Given this list of marker genes SMARCD3, MALT1, EFNB2, C7, IKBKB, EPG5, CD70, SHLD3, SLA2, PYDC5, NFKBIA, FCGR3A, KIR2DL4, IL16, BRD2, LILRA4, NPLOC4, XBP1, IRGM, IGHM (NCBI Gene Id 3507), MIR21, TYRO3, CASP6, MASP1, LBP, IL5, MYO18A, SHB, IL4I1, PIK3CD, ELP6, LRCH4, PRKCB, TACR1, BTN3A2, ZBP1, ACOD1, CSK, PCBP2, XRCC6, ZDHHC9, THY1, USP29, IPO5, CD4, CD7, BRCC3, SLAMF1, CD1E, ZNRF4, DPP4, NFKBIZ, AGER (advanced glycosylation end-product specific receptor), BANK1, CLCF1, CD40LG, EIF2B4, CD38 (NCBI Gene Id 952), GBP2, BTN2A1, PPP2R3C, C1R, GPR151, EBI3, TRAF6, STX4, HSPA8, MIR520B, HHLA2, CD247, CCR7, HMCES, EFNB1, TRIM41, LGALS9 (galectin 9), TAFA3, ARID1A, TRIM31, KLK7, S100A14, ZFP36L1, C5, MZB1, PLA2G5, FCGR1A, BTNL2, C1QBP, PYHIN1, CCR2, GCSAML, SQSTM1, F7, HEXIM1, HLA-DRB1, FBXL2, HDAC6, CD177, KRT1, OGT, BTNL8, TEC, PLA2G3, STAP1, IL7, PPT1, RTN4, MED23, PARP9, BTNL10P, SIRPG, PLA2G4A, ACTB (actin beta), MADCAM1, PLVAP, IL23R (NCBI Gene Id 94006), RBP4, ATAD5, PANX1, STAT5A, ZC3HAV1, CACNB3, MIR19A, POLR3G, PAXIP1, RAET1G, CD86, ULBP2 (UL16 binding protein 2), TRIM15, GPSM3, IKBKE, SMARCE1, DUSP10, KLRK1, PTPRC, CTSG, CXCL12, PTPRJ, C1S, POLR3F, NAGLU, MIR17, TRIM3, IRAK4, MAPKAPK3, RNF185, UBE2N, IGHG4, PPP3CA, C8G, PARK7, POLR3B, SPSB3 (NCBI Gene Id 90864), LAMP1, CLEC4E, BLK, FOS, LRRK2, TRAF3, FCRL3, NFKB1, KCNJ8, CD209, MIR149, EGR3, HLA-DQB2, NCK2, EIF2B1, ZNRF1, IL1R1, PRKCH, IL1A, DNM1L, GPR108, ALPK1, SOCS5, ITGA4, GPRC5B, ADAM17, LAT2, SMARCA4, EEIG1, MSTN, BRD4, SPHK2 (NCBI Gene Id 56848), IL17A, BANF1, PTK2, CCL1, MAP2K6, SHH, RC3H2, SMARCD2, GPATCH3, EVI2B, CPTP, SLC19A1, FYB2, HAVCR1, IL6R, STOML2, CD74, CD46, FPR1, ZDHHC4, ADAM10 (ADAM metallopeptidase domain 10), FZD5, LTF, RNF135, PELI1, AARS2 (alanyl-tRNA synthetase 2, mitochondrial), MIR210, TSLP, C2, DAPK2, PTN, ICOSLG, DDX41, RAC2, ZAP70, SOX4, BTN3A1, LAT, KITLG, CCDC88B, LAX1, PIK3CB, TCF3, EPO, CHUK, OASL, PLPP6, HLA-DQA2, ENPP3, MIR30B, TNFRSF21, TLR1, TLR7, TNFRSF13C (TNF receptor superfamily member 13C), MIR20A, POLR3D, ZCCHC3, ACTL6B, GDI1, FAM3D, GPR33, GATA2, CRLF2, SIVA1, TREM2, TRAF3IP3, MMP8, VSIR, F2RL1, FCGR2B, TNFRSF18, NFAM1, SWAP70, IL23A (NCBI Gene Id 51561), MED1, CXCL13, PARP1, ZBTB7B, STMP1, CD36, PRKD2, THEMIS, EIF2B3, RABGEF1, MIR136, TNFAIP3, B2M, IL6ST, HAVCR2, CYRIB (CYFIP related Rac1 interactor B), FPR3, LCK, XG, DUSP3, C8B, IFNL4, CX3CL1, LATS1, WDFY1, PPP2CA, XRCC5, SMARCC2, PNP, TRIL, UBASH3A, IGLC1, RIPK1, IFNB1, YWHAG, SCIMP, PPP6C, TNFRSF11A, PYCARD, ZDHHC5, FCAR, HCLS1, FCER2, GSDME, NEK7, C1RL, SOX13, CCL2, SPPL3, LACC1, IGF2, MAP3K7, FLOT1, TLR6, IL15, IGLC6, SMPDL3B, ERBIN, PHB1, FFAR3, MIR34A, BMI1, LRRC14, CD3D, SMARCA2, CD79B, CCL20, IGF1, SOS1, TGFBR2 (transforming growth factor beta receptor 2), FFAR2, TNFSF11, DUSP22, CCL8, SERPING1, IL10, IL36B, INAVA, CD244, CD300LB (NCBI Gene Id 124599), NOP53, CD5, KLRD1, FBXO38, LRRC19, IRF5, EXOSC3, HLX, TRIM6, JUND, MIR200B, ITGAM, IRF3, PCID2 (NCBI Gene Id 55795), TRIM62, ARID5A, ZDHHC12, PLA2G7, GPR32P1, MIR130A, CORO1A, PRKCA, TNFSF14, SH2B2, P4HB, FCN3 (NCBI Gene Id 8547), SPACA3, MEFV, CD1A, USP27X, KCNN4, JAK2, SPON2, CHRNB2, CD160, SLC9B2, TBK1, IFNL2, MASP2 (MBL associated serine protease 2), CTSS, RBM14, DDX3X, PRLR, C8A, PLA2G1B, C1QA, MIR140, UBR2, SMARCB1, TKFC, IL4R (NCBI Gene Id 3566), HLA-DRB3, IGHG1, CCL5, CCR1, NOD2, NCKAP1L, GLI2, ZP4, CD80, RASAL3, PTPN6, LGALS3, NR5A2, NOD1, LIPA, CD22, TNFRSF14 (NCBI Gene Id 93208), SELE, GLI3, SRC, CLEC7A, MAP3K8, MYD88, HLA-DQA1, RUNX3, SELP, LILRB4, ADA, EP300, GPR32, KCNK6, PRKCD, TGFB1, HLA-DPB1, PYDC1, CREBBP, RNF39, ELANE, KARS1, OCSTAMP, RNF125, GPR68, ITGA2, TRAF2, DDRGK1, FLT3LG, KAT5, DHX9, BCAR1, LCP2, C5AR2, IL12A, ABL2 (NCBI Gene Id 27), YES1, UBE2K, CD3G, PRKD1, MARK4, FCMR, EDN1, LGR4, IL18RAP, CAMK1D, TARBP2, CD8A, HLA-F, KLRC3, UBQLN1, PERP, PTK2B, STK11, IL12RB1, NR1H4, IL27RA, GPR65, LETMD1, SEC14L1, TIFAB, TRAT1, ZDHHC1, DHX58, ICOS, FADD, CD59, IKBKG, C1QC, CACTIN, TLR2, PIK3R6, JAM2, KHDRBS1, BCL6, SLC7A5, HSP90AA1, VAMP8, IGKC, PRKCZ, PVR, CD276, TRDC, HSPA1A, HLA-DRB5, BTN2A2, CBLB, PHF10, RAB7B, EDN2, MLH1, RIOK3 (RIO kinase 3), TRIB1, ATAT1, MTOR, SEMA7A, CD1D, IGHG3, CXCL10, TOMM70, FUT7, CCL3, ABHD17A, SASH3, MIR142, IL33, VAV1, VAV2, CD1C, SLC11A1, LPXN, TYROBP, CFB, STXBP1, TRBC1, ZP3, BST1, SLC15A4, LSM14A, IGHD, AKIRIN2, RFTN1, FCHO1, LILRB2, FYN, PDE4B, TRPV4, HLA-C, FOXJ1, LEF1, IL20, CD55, THBS4, ZNF580, MOSPD2, CAV1, PHB2, HLA-A, SHLD2, PLA2G6, NAGK, RAET1L, OTULIN, LAMP2, MOG, MS4A1, IGHE, CLPB, GPR31, RPL13A, TNFRSF4, CPT1A, VNN1, BTK, NMI, PIK3R1, ZMIZ1, IRF4, FCN1, RIGI, GPLD1, KLRC4-KLRK1, TOX, ASCL2, PAK1, A2M, ID2, LEP, RELA, PHPT1, CD2, IFNK, IGLC7, PAK2, ITGA2B, ULBP3, VSIG4, NOS2, YWHAE, SIRPB1, FPR2, TRIM56, NCK1, RARA, EREG, CALCA, FOXO3, C5AR1, KIR2DS2, CCR6, JAM3, FYB1, GRAMD4 (NCBI Gene Id 23151), MYO1G, GAS6, TNIP1, AQP3, VEGFA, MAPK1, KLRC2, CD2AP, NCR3, TIRAP, CD27, BTNL3, WASHC4, SOCS1, CFI, MIR520E, PRAM1 (NCBI Gene Id 84106), EIF2B2, VAV3, CD6, SLC15A2, TESC, NOTCH2, SHLD1, UNC93B1, ADAM8, NR1H3, CCDC134, TMIGD3, AKIRIN1, RNF34, BTN1A1, TESPA1, PRNP (prion protein (Kanno blood group)), TTBK1, CD28, TAC1, CREB3, RC3H1, SPI1, BAG6, C4B, AP1G1, IL2RA, USP50, HES1, FOSL1, SIRT1, DHPS, CD99 (NCBI Gene Id 8279), ECSIT, KCNK13, IFIH1, LGALS1, PIK3CA, CD101, TLR8, IL21, MIF, ARID1B, PBRM1 (polybromo 1), HLA-G, TRBC2, BTRC, IGFBP2, CLECL1P, PTPRS, HLA-DOB, IL2RG, SUSD4, C9, TICAM2, TLR10, DDX1 (NCBI Gene Id 1653), CRTAM, TGFB2, CD8B, MIR4691, APP, EIF2B5, KIT, STING1, RASGRP1, TNFSF9, PDE4D, TREX1 (three prime repair exonuclease 1), IRS2, MEF2C, NLRC5, ICAM1, FCN2, GALNT2, ZNFX1, PPARGC1B (PPARG coactivator 1 beta), AMBRA1, FCER1G, CRKL, CR2, TNIP2, MARCHF5, APPL2, CADM1, TRAC, NLRP6, LY96, THEMIS2, ITPRIPL1, CD320, AURKB, APPL1, ARRB2, LILRA2, OPA1, LAG3, CCL19, VTCN1, AP3B1, EPHB2, MIR18A, MIR128-1, TNFSF13B (NCBI Gene Id 89794), CDKN1A, TSPAN6, TP53BP1, IL34, EXOSC6, CFD, NINJ1, CD24 (CD24 molecule), DGKZ, IL18R1, TBX21, PTPN2, HCAR2, AIF1, RIPK2, SKAP1, TNF, NLRP2B, ANXA1, GATA1, CD300A, CMKLR1, BTN3A3, SMARCC1, DNAJB9, PDGFD, BRD7 (bromodomain containing 7), CSF1R, TREML4, SMARCD1, PRKCQ, WNT3A (NCBI Gene Id 89780), ABHD8, HLA-DRB4, NKAP (NCBI Gene Id 79576), FLOT2, IRAK3, IGHA2, HAX1, IFNL1, PDCD1LG2, C17orf99, RPS6KA3, CAMK4, NLRC4 (NLR family CARD domain containing 4), GBP5, PDPK1, P2RY12, ERMAP, SLC15A3, IFNG, RHOH, IFI35, RNF115, CREB1, TXK, CCL4, POU4F1, TIFA, NONO, CD200, SYK, MATR3, ZNF335, KLK5, CSF1, CFHR5, IFI16, CD226, TMEM64, HRG, TMIGD2, EDN3, SPG21 (NCBI Gene Id 51324), BMX, TAP2, INPP5D, TLR5, HSPA1B, RB1, LGALS8, HCFC2, RIPOR2, DHX33, LIME1, BAD, SLC22A13, PCK1, PLPP4, LYPLAL1, GPS2 (G protein pathway suppressor 2), VCAM1, FOSL2, PTPN11, OAS1, ARID2, LIF, KLF10, MAPK3, SPN, KLHL22, HLA-H, ANO6, OXSR1, TRIM5, CX3CR1, BPIFB1, NLRP10, GPI, BLOC1S3, CTSC, PMS2, HSP90B1, NAIP, SFPQ, IGHA1, LILRB1, PLD2 (NCBI Gene Id 5338), MAVS, TNIP3 (TNFAIP3 interacting protein 3), CLEC6A, CASP1, MMP12, MCU, MIR145, HSPD1, ADORA2B, CR1, AP3D1, P2RX7, VAMP3, MAPKAPK2, MIA3, RBM47, NLRP1, BECN1, IRF1, PQBP1, CD99L2, DAB2IP, PLEKHA1, CD5L, LTA, DEFB131A, KLHL25, NECTIN2, DCSTAMP, ITK, CFHR4, SCARA3, C1QB, COLEC11, SLAMF6, LATS2 (NCBI Gene Id 95108), AKT1, HTR2A, DOCK8, LYVE1, ZNF683, GBP1, IRAK1, TLR3, HLA-DMB, PAWR, SMPDL3A, RAB29, MDK, AIM2, PVRIG, C6, VAMP7, NLRX1, CD83, NFKBIL1, SLC39A10, USP15, FUT4, XCL1, SOX12, CCL7, ARG1, DHX36, TLR9, RHOA, GPR183, RAET1E, CGAS, MR1, CD14, GATA3, CLNK, STAT5B, KLK3, DENND1B, GPAM, HSPH1, C4BPB (complement component 4 binding protein beta), PJA2, TICAM1, TMEM126A, CEBPA, AXL, NR1D1 (NCBI Gene Id 9572), MIR708, TM4SF19, CMTM3, CD37, RIF1 (NCBI Gene Id 55183), IL18, CLEC4D, IL1RL2, TASL, COLEC12, CARD11, FER, IL6, HLA-DMA, CD3E, GRB2, SIRPA, KMT5B, IL2, SLC39A6, IL7R, VEGFD, ZDHHC3, POU4F2, LAPTM5, SART1 (NCBI Gene Id 9092), SIN3A, ZBTB16, LYN, PRKCE, HMSD, EZR, POMC, THBS1 (thrombospondin 1), IL1RL1, FOXP1, CXCL8, NF1, RAP1A, SARM1, ITGB2, HLA-DRA, S100A8, DDX21, ACIN1, PF4, SIRT2, PUM2, RNF31, TRIM11, PAK3, ITGB3, CBFB, PSEN1, NFKBID, HCK, PTPN22, S100A9, CFHR3, IL13, BLNK, KMT5C, C4BPA, TYK2, HPX, ZBTB1, TNFSF18, DNAJA3, XIAP, MMP14, PGC, KLRC4, CD274, STK39 (NCBI Gene Id 27347), VEGFC, MSH2, IHH, HMGB1, PRKDC, PUM1, LGMN, BTN2A3P, PYDC2, MAPK8, LIMK1, S100A7, CEACAM1, IGHG2, TMEM102, CLU, MAD2L2, RAC1, ZC3H12A, PLCG1, MIR200C, BIRC2, CTLA4, C4A, RGCC, OAS3, IRAK2, RSAD2, FOXP3, ITCH, NR4A3, CD79A, VEGFB, TLR4 (NCBI Gene Id 7099), RPS19, CSNK1A1, CALR, IGLC3, GCSAM, IL12B, CFHR1, CD1B, SELENOK, CYLD, KLRC1, TFRC, CD72, CXCL17, NEDD9, IDO1, TRGC2, IL4, FGF10, CD47, KLHL6, ZDHHC18, CFP, SERPINE1, CD40, TNFSF13, SLC7A1, C3, BRAF, RNF144A, SPTA1, MFHAS1, MICB, HK1, TRIM32, FGR, CYBA, CCL24, TRIM25, BDKRB1, RBCK1, RPTOR, HMGB2, PSPC1, RPS3, PGF (NCBI Gene Id 5228), GKN2, HSF1, ITPKB, TAB1, MPL, MIR146A, DDX60, CD81, WNT5A, STAT6, IRF7, HLA-DPA1, AZGP1, CASP8, ESR1 (NCBI Gene Id 2099), C3AR1, HRAS, EIF2AK2, WNK1, MIR486-1, RAB11FIP2, SH2D1B, ELF1, IFNL3, CTNNBIP1, CD300LD, RASGRP4, BCL10, ULBP1, RUNX1, RNF170, OTUD4, HLA-E, TRGC1, FES, PLSCR1, RARRES2, POLR3C, BLOC1S6, ANKRD17, SH3KBP1, USP17L2, SNX4, PRKAA1, DEFB124, GFI1, CARD8, EIF2AK4, CR1L, EFNB3, CD300LF, IL15RA, HLA-B, TAX1BP1, UFD1, PIK3AP1, IL1B, GAB2, ZBTB46, BAX, RAG1, TNFSF4, MBL2, SLC46A2, STX7, MNDA, NLRP3, NLRC3, ABL1, P2RX4, PLCL2, ACTL6A, PLCG2, BCL2, REG3G, HLA-DOA, IL17F (interleukin 17F), TRIM65, CCL21, HLA-DQB1, NFATC2, NSD2, IL13RA1, COLEC10, BIRC3, CACNB4, BTNL9, CD19, SH2D1A, CFH, SECTM1, WNT10B, CFHR2, CARD9, here is a description of the gene set: Any process that activates or increases the frequency, rate, or extent of an immune system process. species: Homo sapiens Human Gene Set: GOBP_POSITIVE_REGULATION_OF_IMMUNE_SYSTEM_PROCESS